Given this list of marker genes Mkln1, Tenm4, Ncapg2, Amy2a3, Cdyl2, Tead1, Rac1, Gpr22, Zeb2, Nap1l1, Myo9b, Grm5, Atg3, Ube2e3, Ppm1g, Usp9x, Snrk (SNF related kinase), Jade3, Amy2a2, Ptgfrn, Mbnl1, Zfand3, Bbx (bobby sox HMG box containing), Otud4, Rps27l, Sgk1, Lhfpl3, Stat3, Fam98a, Slc35a1, Rras2, Plagl2, Yod1, Ldhc, Sgcz, Rsbn1l, Saraf, Mfsd14a (NCBI Gene Id 15247), Zbtb5, Luc7l3 (LUC7-like 3 (S. cerevisiae)), Csgalnact2, Atad1, Snx13, Arhgap32, Zdhhc21, Mtmr6, Amy2a4, Dyrk2, Mkrn3, Nfib (nuclear factor I/B), Nabp1, Tomt, Dcaf5, Atrx, Sdk1, Kcnj3, Tiprl, Drd1, Usp15, Fscn1, Prex2, Crp, Ubr3, Pabpc5, Coro2b, Zeb1, Htr1f, Hcfc1, Mllt3, Ttpal, Zbtb10, Mapk7, Efnb2, Tbc1d15, Tbc1d14, Mtcl2, Cbln2, Rps6ka6, Troap, Bltp3a, Ica1l, Setd7, Wsb1, Egr1, Tnik, Nefm, Caps2, Gnas, Ptp4a1, AI597479, Kics2, Cdc73, Pakap, Padi3, Cpsf6, 2310022B05Rik, here is a description of the gene set: Genes predicted to be targets of miRBase v22 microRNA mmu_miR_690 in miRDB v6.0 with MirTarget v4 prediction scores > 80 (high confidence targets). Mouse Gene Set: MIR_690 from publication Chen Y, Wang X (PMID 31504780) studied in species Mus musculus